The following is a description of a gene set: species: Mus musculus Mouse Gene Set: GOBP_METABOLIC_COMPOUND_SALVAGE Any process which produces a useful metabolic compound from derivatives of it without de novo synthesis, as carried out by individual cells., and this is the list of marker genes: Gmpr, Upp1, Nmrk1, Dck, Gmpr2, Impdh2, Fpgt, Slc35c1, Nmnat1, Ada, Adk, Pgm2, Ampd1, Qng1, Bhmt, Dnph1, Adss2, Pdxk, Aprt, Nadsyn1, Slc2a1, Pnp, Bhmt1b, Bhmt2, Uck1, Dctd, Hprt1, Adi1, Nmnat3, Adsl, Uck2, Fcsk, Ampd3, Pnp2, Naprt, Dguok, Gmps, Adss1 (adenylosuccinate synthase 1), Fuom, Impdh1, Nmnat2, Slc25a51, Ampd2, Mri1, Nampt, Upp2, Cda, Apip, Uckl1, Enoph1, Mtap, Nmrk2